The following is a description of a gene set: Genes predicted to be targets of miRBase v22 microRNA hsa-miR-5590-5p in miRDB v6.0 with MirTarget v4 prediction scores > 80 (high confidence targets). from publication Chen Y, Wang X (PMID 31504780) Human Gene Set: MIR5590_5P species: Homo sapiens, and this is the list of marker genes: TPGS2, LYVE1, OCIAD1, ZBTB2, RRAGD, BAX, MARCHF7, DEPDC4, WDR43, YTHDF3, C18orf63 (chromosome 18 open reading frame 63), CADM2, CHODL, TAF9B, TSC22D2, NAV1, MICU2, LBH, MYLIP, KMT2C, CEMIP2, KIAA0753, ANK3, C5orf15 (NCBI Gene Id 56951), ZC3HAV1, HELZ, SMARCA1, LUZP1, ESR1, FBXO36, TRIM14, SLC9A6, CCDC89, CISD1, RNF169, CLHC1, LYSMD2, ATG2B, MRTFB, ZC3H12C, NKAIN3, ABHD13, ZNF329, FSCB, SPART, RNF145, SS18, IL1R1 (interleukin 1 receptor type 1), ENTHD1, KRT40, KCNJ3, PACSIN2, FGF23, HOOK1, ZNF880, CFAP20DC, B4GALT6, CSTF3, REXO5, SLC35F1, RAN, PTCHD4, MAML1, LPAR1, FBXO30, GGNBP2, C5AR1, IFT122, LYPLA1, ANGPT1, ZIC4, NR3C1, LRAT, ACTL10, CCDC88A (NCBI Gene Id 731560), FRS2, CEP97, CFL2, NPAS4, ZNF695, PREX2, GLIPR1L2, SNX20, HOOK3, ADAT2, BICC1, CACNA1E, TRIM45, ZNF714, TMEM42, ZNF99, USP25, ERO1B, SP100, ASCC3, PAQR5, TAX1BP1, PHF6, SALL1, TENM2, ADAM22, C4orf46, SAXO2 (stabilizer of axonemal microtubules 2), COL11A1, DPY19L1, SCAMP1, WDR35, AFF4, DLG2, CD55, CKAP2, HYPK, EBF1, AGO3, ZNF100, LRRC28, FRMD6